Given this list of marker genes TTC6, PWWP3A, CCNB1, ACAT2, RASSF5, SYT1, UMOD, CPZ, FOXR1, TRMT2B, ARL10, GTPBP10, ATP5F1C, PROK2 (NCBI Gene Id 60675, prokineticin 2), MCL1, NRBP1, DPY30, RAET1L, C6orf89, YTHDF1, IL17D, C2orf76, CLEC4G, BPIFB1, HPCA (hippocalcin), CPLANE2, MRPL3, N4BP2, PLXNA4, KBTBD8, DMPK, GATD3, STK40, EMP2, C12orf54, ANO4, HCAR2, MAPK10, PRDX5, PHC3, PRSS33, H1-10, TAC3, GAL3ST3, ZNF286A, GALNT2, C2orf42 (chromosome 2 open reading frame 42), CLDN15, ZNF416, CXCL5, PIK3CB, CATSPER2, OR56A1, HCFC1, ATP7A, GTF3C2, SCTR (NCBI Gene Id 6344), RTF2, PXK, PIK3R1, MAFF, ZNF827, AGR3, OR13F1, FBXO38, ELK4, SPATA19, TMEM254, FUCA2, CDAN1, SLC37A3, SLC26A11, UBN1, CLNS1A, GPR151, KIF6, LILRB1, ST8SIA4, PGAP4, ECE2, ATP9A, GUK1, THOC7, FRMD5, FOXD3, MSMP (microseminoprotein, prostate associated), KLHL11, TLE6, LRP5L, GPR183, PRXL2C, FGF23, ZNF599, ZAR1, UBE2D2, DNAJC19, TLR8, MRGPRG, ASPSCR1, NXNL2, MCUB, PDK1, NELL2, OR8B4, KERA (keratocan), UBOX5, NEK7, RIMS2, PTMA, CDH6, RBM44, GOLT1B, MRPL20, STX1B, AP1B1 (NCBI Gene Id 162), ASTN2, DYNC2I1, H2AC25, PGM1, SPATA1, SLC24A2, BMP1, IPO13, AK5, TAS1R2, CARD17P, TNFRSF19, HCP5, CHMP2A, CLVS2 (clavesin 2), CSRNP1, RALGDS, ADGRG4, IFTAP, ARPP19, KRBA1, TLE5, CRX, CEP76, IFT27, TOLLIP, CPS1, SH2B3, HLA-E, GPR148 (G protein-coupled receptor 148), PFKFB4, HNRNPA3, AKTIP, MOCS2, EFHC2, TFAP2C, MSRA, STIL, RAB3IL1, TLCD4, LCOR, ENTREP3, SHISAL2A, ZXDA, LINC02870, PARP12, ZNF271P, TBL2, PLAC4, PDE12, ABTB2, ODF1, C9orf40, MARS2, WARS1, PKD1L2, POP5, ODF2, TOP2A, HPDL, ACTL6B, BET1L, CALML6, MYL1, RNASEH2B, UGT1A6, BBS2 (Bardet-Biedl syndrome 2), AMN1, CENPH, PDZD11, CENPK, NAT16, FAM47B (NCBI Gene Id 170062), E2F3, SLC38A10, MIR1915HG, PLEKHG2, CALCOCO2, CDC42EP3, REV3L, LRATD1, PARS2 (NCBI Gene Id 91517), S100A8, GJA10, AGER, RPP40, CDC20B, BTLA, DCAKD, ZNF746, DIRAS1, HNRNPC, SANBR, PCDH17, CHMP2B, SLC9A2 (solute carrier family 9 member A2), DIMT1, ACSL1, C1orf43, GPR158, ZNF396 (zinc finger protein 396), HIP1R, GGA1, FOXD4L1, OR6Y1, NDUFA11, PPY, TRIP11, RELL1, SYTL5, RBM7, VCP, PEX1, PGK1, TPMT, VPS26B, SCGB1D4, LTBP4, MTNAP1, SDR42E1, MZT2A, UAP1, DCAF4, COL11A2, FCGR1BP, LST1, P2RY13, MN1, ZNF57, KRT6B, TMEM201, IRX1, KLRF1, SCRN1, NKRF, ZNF554, ZNF384, GMPPA, BPY2B, GALE (UDP-galactose-4-epimerase), KIAA1958, LETM2, TNFRSF10A, TAP1, NKAIN3, OTX1, CNN1, ZNF831, ITGB1, CIAPIN1, LAMB1, PACC1, STOML2, H2AJ, CYYR1, FBXL16, SBNO1, LGALS9 (NCBI Gene Id 90793), USP9Y, here is a description of the gene set: Genes indentified by RNAi screen as regulating infection of THP-1 cells (macrophage) with Mycobacterium tuberculosis. from publication Kumar D, Nath L, Kamal MA, Varshney A, Jain A, Singh S, Rao KV (PMID 20211141) We performed a genome-wide siRNA screen to identify host factors that regulated pathogen load in human macrophages infected with a virulent strain of Mycobacterium tuberculosis. Iterative rounds of confirmation, followed by validation, identified 275 such molecules that were all found to functionally associate with each other through a dense network of interactions. This network then yielded to a molecular description of the host cell functional modules that were both engaged and perturbed by the pathogen. Importantly, a subscreen against a panel of field isolates revealed that the molecular composition of the host interface varied with both genotype and the phenotypic properties of the pathogen. An analysis of these differences, however, permitted identification of those host factors that were invariantly involved, regardless of the diversification in adaptive mechanisms employed by the pathogen. Interestingly, these factors were found to predominantly function through the regulation of autophagy. studied in species Homo sapiens Human Gene Set: KUMAR_PATHOGEN_LOAD_BY_MACROPHAGES